Given this list of marker genes Map2, Atxn7, Wdr47, Camsap1, Tubb4a, Trim54, Cdh5, Hdgfl3, Tpx2, Stmn2, Apc2, Cib1, Map6d1, Rp1, Mapre1, Clasp1, Ccdc88c, Snca, Sgk1, Specc1l, Arhgef2, Nav3, Diaph3, Clasp2, Bmerb1, Clip3, Gas2l1, Map1a, Ttbk2, Gas2l2, Bbof1, Eml4, Inpp5j, Arhgef7, Katnb1, Camsap2, Camsap3, Map1b, Fgf13, Mid1, Apc, Eml2, Stmn1, Spef1, Dyrk1a, Taok1, Hdac6, Fkbp4, Mid1ip1, Ckap2, Tbcd, here is a description of the gene set: Mouse Gene Set: GOBP_NEGATIVE_REGULATION_OF_MICROTUBULE_POLYMERIZATION_OR_DEPOLYMERIZATION species: Mus musculus Any process that stops, prevents, or reduces the frequency, rate or extent of microtubule polymerization or depolymerization.